Given this list of marker genes PLA2G5, AKR1C3, ALOX15B, GGT5, GGT7, CASP1, PRXL2B, PRG3 (NCBI Gene Id 10394), EDN1, GSTP1, PLA2G4A, CYP1B1, PLA2G4C, FADS1, AKR1C4, LTA4H, SYK (spleen associated tyrosine kinase), GPX1, ATP6V1B1 (ATPase H+ transporting V1 subunit B1), FAAH2, PLA2G10, PTGR2, MGST3, PTGS2, AKR1B1, COMT, MIR766, CYP4F11, PLA2G3, ALOX15, MIR132, CYP4F22, PTGDS, EDN2, HPGDS, PLA2G4F, GSTA1, PTGS1, ALOX5, MGLL, DAGLA, GGT2P, CYP4F8, PTGR1, CES2, MIR204, CD74, CYP1A1, FABP5, GGTLC3, PTGES, FAAH, ALOX12B (NCBI Gene Id 242), HPGD, PNPLA8, GGTLC2, ABCC10, PTGES3, AVPR1A, CYP2C9, CYP2S1, MIF, CYP2E1, EPHX1, PYCARD, PLA2G1B, CYP2J2, NAIP, SIRT1, CYP4Z1, CYP4A22, ALOXE3, CYP2U1, ACOX1, LTC4S, CYP2A13, ALOX12, AWAT1, CYP2C19, DAGLB (diacylglycerol lipase beta), CYP4F2, PLAA, GGTLC1, GGTA1, AVP, MGST2, CYP1A2, TNFRSF1A, GSTM1, GGT1, DPEP1, CYP2A7, PLA2G4B, CYP2C8, CYP2F1, MAPKAPK2, NCF1, CBR1, GGT6, CTHRC1 (collagen triple helix repeat containing 1), ABHD6, AKR1C2, CYP4A11, IL1B (NCBI Gene Id 3553), DPEP2, PIBF1, CYP4F12, CYP2B6, CYP2A6, PTGIS, CPA1, CYP2D6, PTGES2, CYP2C18, GGT3P, ABCC1, NLRC4, CYP4F3, GPX4, ABHD12, TBXAS1, ALOX5AP, PLA2G2F, AKR1C1 (aldo-keto reductase family 1 member C1), here is a description of the gene set: The chemical reactions and pathways involving icosanoids, any of a group of C20 polyunsaturated fatty acids. studied in species Homo sapiens Human Gene Set: GOBP_ICOSANOID_METABOLIC_PROCESS